Given this list of marker genes MDP1, IL10RB-DT, CIDEB (NCBI Gene Id 27141), KDM4A-AS1, RSC1A1, here is a description of the gene set: Genes down-regulated in B cell 3d vs 0d in adults after exposure to 2011-2012 trivalent inactivated vaccine (A/California/7/09 (H1N1), A/Perth /16/2009 (H3N2), B/Brisbane/60/2008), time point 3D. Comment: Down-regulated DE RNA transcripts (down >= 1.5x) shared between both TIV-vaccinated donors studied in species Homo sapiens Systems biology is an approach to comprehensively study complex interactions within a biological system. Most published systems vaccinology studies have utilized whole blood or peripheral blood mononuclear cells (PBMC) to monitor the immune response after vaccination. Because human blood is comprised of multiple hematopoietic cell types, the potential for masking responses of under-represented cell populations is increased when analyzing whole blood or PBMC. To investigate the contribution of individual cell types to the immune response after vaccination, we established a rapid and efficient method to purify human T and B cells, natural killer (NK) cells, myeloid dendritic cells (mDC), monocytes, and neutrophils from fresh venous blood. Purified cells were fractionated and processed in a single day. RNA-Seq and quantitative shotgun proteomics were performed to determine expression profiles for each cell type prior to and after inactivated seasonal influenza vaccination. Our results show that transcriptomic and proteomic profiles generated from purified immune cells differ significantly from PBMC. Differential expression analysis for each immune cell type also shows unique transcriptomic and proteomic expression profiles as well as changing biological networks at early time points after vaccination. This cell type-specific information provides a more comprehensive approach to monitor vaccine responses. from publication Hoek KL, Samir P, Howard LM, Niu X, Prasad N, Galassie A, Liu Q, Allos TM, Floyd KA, Guo Y, Shyr Y, Levy SE, Joyce S, Edwards KM, Link AJ (PMID 25706537) Human Gene Set: HOEK_B_CELL_2011_2012_TIV_ADULT_3DY_DN